Given this list of marker genes Brcc3dc, Babam2, Babam1, Mpnd, Uimc1, Abraxas1, Bard1, Brcc3, Brca1, here is a description of the gene set: A protein complex that contains the BRCA1-BARD1 heterodimer, RAP80/UIMC1, BRCC3/BRCC36, BRE/BRCC45, FAM175A/CCDC98/Abraxas and MERIT40/NBA1, and specifically recognizes and binds K63-linked polyubiquitin chains present on histone H2A and H2AX at DNA damage sites. Mouse Gene Set: GOCC_BRCA1_A_COMPLEX species: Mus musculus